Given this list of marker genes PCYT1B, THBS1, FSHR, NR2C2, CCND2, IGF1, UBE3A, NOS1, SH2B1, SRC, TAF4B, DDR2, AHR, here is a description of the gene set: species: Homo sapiens Human Gene Set: MATZUK_EARLY_ANTRAL_FOLLICLE from publication Matzuk MM, Lamb DJ (PMID 18989307) Reproduction is required for the survival of all mammalian species, and thousands of essential 'sex' genes are conserved through evolution. Basic research helps to define these genes and the mechanisms responsible for the development, function and regulation of the male and female reproductive systems. However, many infertile couples continue to be labeled with the diagnosis of idiopathic infertility or given descriptive diagnoses that do not provide a cause for their defect. For other individuals with a known etiology, effective cures are lacking, although their infertility is often bypassed with assisted reproductive technologies (ART), some accompanied by safety or ethical concerns. Certainly, progress in the field of reproduction has been realized in the twenty-first century with advances in the understanding of the regulation of fertility, with the production of over 400 mutant mouse models with a reproductive phenotype and with the promise of regenerative gonadal stem cells. Indeed, the past six years have witnessed a virtual explosion in the identification of gene mutations or polymorphisms that cause or are linked to human infertility. Translation of these findings to the clinic remains slow, however, as do new methods to diagnose and treat infertile couples. Additionally, new approaches to contraception remain elusive. Nevertheless, the basic and clinical advances in the understanding of the molecular controls of reproduction are impressive and will ultimately improve patient care. Genes important for early anral follicle, based on mouse models with female fertility defects.